Given this list of marker genes Akt2, Xiap (NCBI Gene Id 74774, X-linked inhibitor of apoptosis), Fyn, Dock1, Raf1, Mapk1, Tesk2, Pik3cg, Akt3 (NCBI Gene Id 98462), Selenop, Birc2, Pik3ca, Pdgfrb, Pak2, Mapk8, Mtor, Cav1, Pak3, Apaf1, Mapk7, Mapk12, Grb2, Atp1a1, Ccnd1, Cav2, Ccnd2, Srms, Pdgfra, Pten, Pak5, Ctnnb1, Ptk6, Pik3r1, Birc3, Rac2, Map2k5 (mitogen-activated protein kinase kinase 5), Map2k3, Crk, Egfr, Mapk4, Kdr, Casp3, Bcar1, Araf, Ilk, Hras, Pak1, Rac3, Bcl2, Cav3, Map2k6, Txk (TXK tyrosine kinase), Jun, Rap1b, Sos1, Ptk2, Shc1, Pik3r4, Hck, Erbb2, Pik3r2, Src, Pik3r5, Shc3, Cyct (cytochrome c, testis), Rac1, Mapk6 (NCBI Gene Id 70413), Pik3cb, Gsk3b, Tnk1, Igf1r, Map2k2, Styk1, Crkl, Casp9, Akt1, Pik3cd, Rap1a, Braf, Pak6, Vav1, Fgr, Map2k1, Atp1b1, Tnk2, Cycs, Bad, Met, Rapgef1, Pak4, Mapk9, Ccnd3, Blk, Flt1, Elk1, here is a description of the gene set: species: Mus musculus Na/K-ATPase/Src signaling Mouse Gene Set: WP_NAKATPASESRC_SIGNALING